Given this list of marker genes LEMD2, TM7SF2, MAJIN, TOR1AIP1, LMNB1, DPY19L2, NUTF2, LBR, TMEM201, KCNH1, UNC50, MFSD10, IFI27, PSEN2 (presenilin 2), TMPO, SMAD3, SIRT1, ITPR1 (NCBI Gene Id 619543), FAM209A, ATP1B4, NEMP1, GHRHR, EMD, NEMP2, MATR3, SIGMAR1, TRA2B, SPAG4, ARL6IP6, TMEM120A, DPY19L2P2, NRM, P2RX6, PLPP6, FAM209B, FAM169A, TMEM120B, SUN3, TMEM43, NPAP1, SMAD1, LEMD3, PTGS2, TERB1, SUN1, ATP11B, IFFO1, LRPPRC, ERN1, RNF13, TMX4, CBX3, TERB2, SUN5, SUN2, ZMPSTE24, here is a description of the gene set: The inner, i.e. lumen-facing, lipid bilayer of the nuclear envelope. species: Homo sapiens Human Gene Set: GOCC_NUCLEAR_INNER_MEMBRANE